The following is a description of a gene set: studied in species Homo sapiens An anomaly of the rhythm or depth of breathing. Human Gene Set: HP_ABNORMAL_PATTERN_OF_RESPIRATION Abnormal pattern of respiration, and this is the list of marker genes: NAA10, CLPB, BMPR2, ATXN2, NUMA1, EIF4A2, AK9, CRYAB, TGFB2, DOLK, SCO1, CFL2, CHRNE, ATP5MK, IL12B, ERBB4, CAMK2B, TWNK, STN1, PGM1, TBX20, PRDM16, MTM1, MCCC1, PTCH1, EPHB4, CHRNB2, COL6A1, TOE1 (target of EGR1, exonuclease), AIFM1, GNA11, MAT2A, PON1, SCN4A, AMER1, CRIPTO (cripto, EGF-CFC family member), KCNE2, LRP4, CHRNA1, TPM3, MYLK, DPAGT1, TMEM216, PLEC, GABBR2, TMEM67, DHX16, RANBP2, MKS1, AGR2, MT-ND1, BUB3, SLC25A4, RPL3L, NDN, LYRM4, HMGCR, AHI1, BUB1B, HCCS (holocytochrome c synthase), RBM10, SRPX2, ARMC9, TPI1, RAPSN, PCCA, TGFBR2, MT-TN, WFS1, NDUFS1, SUCLG1, UBA1, TK2, TLK2, KCNJ2, TRIP11, RRM2B, PON2, FGFR2, COL2A1 (collagen type II alpha 1 chain), TNNC1, COX11, TGFB3, SCN8A, ACADVL, LRPPRC, CEP57, DPM2, TRIP13, NPM1, NDUFAF2, CDC45, SNORD115-1, ABCC6, WIPF1, BTD, INPP5E, SQSTM1, LIFR, OTX2, COL12A1, GAA, FOXF1, PNPLA2, CISD2, NEFH, SIX3 (SIX homeobox 3), SETD2, B9D2, SCN2B, COL1A2, MGME1, CBY1, SCNN1B, MOGS, MRPL39, DNAJC21, GLT8D1, DNASE1L3, ABCG5, NRXN1, PUF60, SNORD116-1, CFAP410, MT-ATP6, VAPB (VAMP associated protein B and C), ETFB, TNFSF11, CPT2, COL4A6, BCHE, PRKAR1A, ORC6, POT1, FHL2, PPARGC1A, RARA, ABCC9, MT-ND5, CEP290, CCNF, SATB2, SPP1, IPO8, ARL3, FARS2, TSEN34, SLC25A20, MKRN3, NAGS, VCL, PIEZO2, MFAP5, ETFA, RAF1, GATA4, CSF2RB, NKX2-5, TLL1, STAT4, GOSR2, FGF13, POU6F2, WDR45B, ABCD4 (NCBI Gene Id 5826), BRCA2, CHRNB1, ZIC2, MUSK, MT-ND6, NALCN, NPPA, POLG (DNA polymerase gamma, catalytic subunit), PLA2G6, SLC25A1, IKZF1, DSC2, SCN4B, DCTN1, ETFDH, THSD4, SETBP1, COQ4, SMAD3, CSF2RA, GJA5, PDHA1, PKP2, TNNI3, GABRG2, PRRX1, TERT, HSPG2, KCNE1, MT-TV, NDUFV1, CIZ1, NACC1, ACY1, UBQLN2, MYL4, GATA5, TBK1, PRKG1, REST, MPC1, LGI4, BTNL2, PSAP, YARS2, SCO2, CHRNA2, MATR3, HACD1, ZC4H2, PRNP, DDC, CYB5A, SYT1, KIAA0753, ACTN2 (NCBI Gene Id 88), DAO, COL4A5, PYGM (glycogen phosphorylase, muscle associated), SLC18A3, ATP5F1D, GLE1, KCNA5, PTF1A, SH3TC2, ZFPM2, ATP13A3, MMUT, PRPH, ENG, SUFU, JPH2, ATP5F1B, NPHP1, HLA-DPB1, CREBBP, MT-CYB, FBP1, GRIN1, CAPNS1, GAS1, VCP, KATNIP, SLC2A1, TMEM107, STIL, SRP54, FOXH1, SFTPA1, CA5A, ANXA11, SCN5A (sodium voltage-gated channel alpha subunit 5), SDHA, PRKAG2, MT-ND4, MPV17, DBH, ATP5F1E, LMNA, BUB1, KIT, CACNA1A, BRAT1, ADAMTS13, ZMPSTE24, ASCL1, GLI2, CAV1, KIF5A, TRMT5, ACTA1, SMPD1, PAM16, COLQ, PDE6D, CACNA1S, MT-ATP8, STAG2, CCN2, ADCY6, BMPER, BAP1, SCN1B, TTC19, ORC1, CNTNAP1, ERGIC1, TGIF1, TRIM28, MAGEL2, NR4A2, ALK, TOPORS, KIF20A (kinesin family member 20A), ECHS1 (NCBI Gene Id 1892), IFT81, SIK1, RNU4ATAC, MMAA, KRT6B, SLC25A15, NODAL, FLNC, GMNN, ACADS, PITX2, TP63, TSC1, KCNQ2, PI4KA, ACADSB, KRT16, TAFAZZIN, MMAB, ACADM, PURA (purine rich element binding protein A), UNC13A, DLL1, IFT74, HLCS, HMGCL, KCNQ1, ALPL, RBM20, MARS1, SYT2, CEP104, SLC25A12, SCN3B, PON3, TBC1D24, MMACHC, ATP5F1A, LAMC2, CEP41, ATP11A, OPA1, CITED2, RELN, CFTR, NDUFA11, JRK, TRPV6, ASAH1, POLG2, CRLF1, MGAT2, SKI, MYL3, POMT1, DPP9, OXCT1, PARN, DISP1, PSAT1, SFTPB, GPC3, FOXP3, SHH, VAMP1, TUBB4A, TSFM, CABP4, MYZAP, ELN, HACE1, TAF15, GPHN, PFN1, MECP2, PWRN1, IFNG, DNAJB4, MT-ND3, TARDBP, LRP5, DNA2, DMPK, NEK1, HERC2, FZR1, RPGRIP1L, NDUFA8, SMC5, DSP, CDKL5, TMPO, TCTN3 (NCBI Gene Id 26123), NDE1, LAMB3, TCTN2, TRMU, NEXN, GRIK2, KRT6A, GLA, TET2, IRF6, TXNRD2, KAT6B, HLA-DRB1, LAMA3, GLS, ADGRG1, SGCD, GATAD1, VEZF1, FAM149B1, ATPAF2, KIF7, COL6A3, LOX, EDN1, MAPT, SNAP25, HAND2, FGFR3, MT-ND2, IL1RN, SNX10, TSPYL1, DST, FLNA, PRKCSH, ASL, FBN1 (fibrillin 1), SMAD2, CEP120, HSPD1, MYBPC3, IRF2BP2 (interferon regulatory factor 2 binding protein 2), ATP1A2, KRT17, NDUFS2, CRH, LYRM7, PWAR1, PKHD1, SLC1A3, EOMES, COL13A1, MLX, EP300, PCCB, IDH1, RTEL1, LMOD3, SAT1, HOXA1, CSRP3, COA8, CDC6, SLC12A3, LDLR, SEC63, BICD2, TCIRG1, RYR1, SELENON, SCNN1A, SOX9, IFIH1, CRLS1, RHD (Rh blood group D antigen), TMEM218, CNTNAP2, EDA, BCOR, APOB, FAM13A, WT1, DSG2, MYH6, DIS3L2, ABCA3, TMEM237, KIAA0586, CASK, HBB, NDUFS6, PIBF1, ADAM22, SMC1A (NCBI Gene Id 8243), TERC, MYH11, AGRN, NGLY1, TCF4, LRP12, HLA-B, TGFBR1, ABCG8, COPA, FDX2, GATA6, TFG, ENPP1, KLHL7, GNAI3, MYO9A, GLRA1, CASR, GNB2, CLCN7, TNNT2, NABP1, TPM1, WAS, TCAP, SFTPA2, MT-TW, MTR, LDLRAP1, NDUFA2 (NADH:ubiquinone oxidoreductase subunit A2), CCR6, PCK1, SOD1, OFD1, LMOD2, DEPDC5, LMO1, SURF1, DNAJB6, NHLRC2, STT3B, GABRB3, COL25A1, KCNQ3, ALAS2, STAT2, NOD2 (NCBI Gene Id 8135), PSEN2 (NCBI Gene Id 5664), ZNF423, COL6A2, PLAA, SCNN1G, NDUFS4, ASXL1, MYL1, KATNB1, RPS28, NECTIN1, SEPSECS, MSX1, SERPING1, DOK7, UQCRC2, MT-TK (mitochondrially encoded tRNA-Lys (AAA/G)), FUS, LDB3, PLPBP, MT-TE, TSEN15, TSEN2, KCNJ6, MYOZ2, TAF1A, HEY2, RUNX2, MYCN, TSC2, FIG4 (NCBI Gene Id 9896), DNAAF3, ACAT1, KLHL24, LTBP3, STING1, ARSL, KCNJ11, PLCB4 (phospholipase C beta 4), NKX2-6, TCTN1, HYLS1, UBE3B, SNRPN, TMEM126B, RPS26, KCNJ3, CC2D2A, RAP1GDS1, ADNP, IGHMBP2, ORC4, SCN2A, LIAS, ANKRD1, MRPL3, ANG, GABRA1, LBX1 (ladybird homeobox 1), TBR1, PEX13, TINF2, ISCU (iron-sulfur cluster assembly enzyme), GNAS, SLC52A3, CHAT, AARS1 (alanyl-tRNA synthetase 1), DZIP1L, CHCHD10, HNRNPK, SFTPC, RHCE, LAMB2, KCNJ5, ITGA3, PLXND1, CHRNA4, CPLANE1, LAMA4, MYPN, MUC5B, CDON, SMARCAL1 (NCBI Gene Id 50485), EPOR, COA6, PHOX2B, VPS33A, REEP1, TP73, FKTN, TMEM138, ATRX, NDUFS8, GLUL, DMD, ERF, SLC39A8, SDCCAG8, PNKD (PNKD metallo-beta-lactamase domain containing), TBL1XR1, FKRP, TPM2, RNU4-2, MYL2, NTNG1, ARX, NDUFB11, TMEM231, HDAC9, KAT6A, IRAK1, D2HGDH, ARL13B, DYNC2LI1, KLHL41, NUP214, B9D1, FIP1L1, FGFR1, BAG3, PEX5, TRPM4, BANF1, FGF8, CLCNKB, TTN, GBA1, PLCH1, TOGARAM1, NDUFA6, MYH7, EFTUD2, GALC, RHAG, SLC22A5, NFIX, ALG12, BOLA3, SH2B3, ALMS1, P4HTM, RET, AGO2, OCA2, ATP1A3, IRF5, ACTA2, MTHFR, PRRT2, TRAK1, FARSB, ATP6V1B2, FAM20C, KCNT1, SLC34A2, NUP155, SBDS, SSR4, SCYL2, COX7B, ZIC3, H19, IL6ST, MEGF10, NEMF, MYO1H, ZBTB16 (zinc finger and BTB domain containing 16), LONP1, EIF2AK4, USP9X, PCSK9, LAMA2 (NCBI Gene Id 3908), TECPR2, CAP2, SLC6A5, SLC35A1, HDAC4, PSEN1, NPAP1, CHMP2B, SLC6A9 (NCBI Gene Id 6536), B2M, UQCRFS1, GTPBP3, KCNA1, OPTN, TSEN54 (tRNA splicing endonuclease subunit 54), CHRND, MINPP1 (NCBI Gene Id 9562), CYB5R3, GET3, SERPINH1, XPNPEP2, DPM1, NEB, SLC25A3, RNF13, CSPP1, TBX4, AP3D1, PLN, DES, ACTC1, GCSH, TREM2, RARS2, TBX1, APOA1, HNRNPA1, TFAM, IFT52, NKX2-1, HTRA2, NAXE, PPCS, SMAD4, JAK2, CACNA1H, CDT1, WAC, PIGT, LIN28B, STX16, STAT3, RNF125, ACVRL1, CTSD, GYG1, SLC2A10, B3GALT6, PIGA, MYT1L, FOXE3, SERPINA1, PML, MT-TL1, PMM2, BAG5, STAT5B, PPP1R21, SLC5A7, COQ7, SLC31A1